The following is a description of a gene set: Human Gene Set: GOBP_PEPTIDYL_CYSTEINE_MODIFICATION species: Homo sapiens The modification of peptidyl-cysteine., and this is the list of marker genes: HHAT, ZDHHC14, ZDHHC15, NOS2, ZDHHC7, GOLGA7, RAB6A, ZDHHC9, ZDHHC11, GAPDH, ZDHHC12, TXN, S100A8, ZDHHC18, ZDHHC21, ZDHHC8, ZDHHC19, ZDHHC20, CLIP3, ZDHHC2, S100A9, ZDHHC3